Given this list of marker genes UNC93B1, TGFB1, YEATS2, BMPR1A, SCN1A, DNAI1, ADAMTS3, IRAK1, CD46, CTNND2, SH2B1, ZNF365, CFI, MDH2 (malate dehydrogenase 2), IFIH1, ANO1, ATRX, CDKN1B, HLA-B, TRAF7, SELENON, SLC25A4, ZFHX2, NFIX, IL12B, TNFRSF11A, HCRT, PIGA, GDF2, MAOA (NCBI Gene Id 441491), SAMHD1, NPPA, FAS, KIF23, TBC1D8B, TRAF3, SMAD3, MRPS2, MYD88, JAG1, CDKN2B, HELLPAR, CORIN, MAGI2, SMARCAL1, NOTCH2, PLAAT3, MSX2, DEPDC5, NR3C1, KCNA1, EPM2A, PDCD10, PRTN3, MECR, HLA-DPA1, GAPVD1, FASLG, SDHB, GNB2, MT-TL1, MEN1, MT-ND4, ITGA7, GP9, EPOR, MT-ATP6, STOX1, HLA-DQB1, SLC39A14, CCR1, TICAM1, SDHD, MLX, APC, TPM3, MT-TW, RNU7-1, RELN, SMARCE1, STIM1, SLC25A11, IL12A, UBAC2, ACP5, RNASEH1, JAK2, NOTCH3, PTPRO, FLI1, CDH23, ELANE, TBK1, SMO, EPAS1, AMACR, SPOP, C4A, LRP5, NOP56, TREX1, MT-TH, GABRG2, MOG, NRAS, SLC2A1, NAA60, PDGFRB, MLH1, MSH2 (mutS homolog 2), APOL1, HLA-DPB1, ESR1, USP48, HTRA1, NHLRC1, TPM2, CTLA4, TRPC6, LPIN2, PRRT2, KLRC4, POLG, RASA1, HTR1A, ZEB2, SCN2A, CSNK1D, CYP11B2, SMARCB1, NFE2L2, RAF1, ADAR, IL23R, ACVRL1, NUP85, PDGFB, SRPX2, NUP107, TNFSF4 (TNF superfamily member 4), SUFU (SUFU negative regulator of hedgehog signaling), CTNNB1, KCNJ5, TLR3, TTR, CASP10, ANKFY1, KYNU, GDF3, MARCHF6, RACGAP1, FLT1, ZFTA, NDP, TMEM127, AKT1, CPT2, PGK1, CACNA1A, MT-ND6, AMER1, KCNQ2, TWNK, SRSF2, PLCE1, CLCN2, STAT4 (signal transducer and activator of transcription 4), COL5A2, RNASEH2C, ACTA1, MCAT, NUP160, GP1BB, SLC12A3, PIK3CA, SEMA4A, RRM2B, ALK, CYB5R3, SMAD2, MTHFR, CFH, NLRP3, AIP, COL4A3, TRANK1, VANGL1, MPL, MRPL39, OPA1, NUP205, PMS2, CNTN2, SDHC, MT-ND1, USP8, TET2, RET, DNM1L, FGFR2, ASXL1, EMP2, SH2B3, PTEN, NF2 (NF2, moesin-ezrin-radixin like (MERLIN) tumor suppressor), CLCNKB, PAX2, BRCA2, SAT1, GCDH, TGFBR2, P2RY11, LSM11, IL10, ERF, RNASEH2A, STARD7, BRAF, NLRP12, NAGS, SLC19A2, HACD1, AP2S1, COPB1, RPS20, VHL, EPHB4, CD2AP, NPHS2, GP1BA, GATA2, COL1A1, KRIT1, MAP3K20, MSH6, EPCAM, LYN, RNF168, DNMT3A, GNAQ, TP53, GRIN2A, CTSH, PRORP, MEFV, ENG, KIT, KL, SLC1A3, SMAD4, VSX1, SAMD12, MYO1E, ANLN, POLE, MT-TF, LGI1, DKK1, IL12A-AS1, F8, MT-CO1, BCAT2, CACNA1D, WT1, PEX11B, CALR, FARSB, GPR101, NF1, MT-ND5, MUTYH, GDF6, CCND1, ACTN4, ACSF3, BAP1, CHEK2, POLG2, HLA-DRB1 (major histocompatibility complex, class II, DR beta 1), ADAMTSL1, CDKN1A, RYR1, RNASEH2B, FGFR3, MYORG, POLD1, IRF3, PIGT, SCN5A (sodium voltage-gated channel alpha subunit 5), MT-TC, TNF, CLTRN, IFNGR1, CRB2, KRAS, SPP1, CCM2, TLR7, CDKN2C, COL4A1, ATM, MT-TQ, PMS1, SQOR, MVK, TERT, ARHGDIA, GBA1, ADA2, COQ8B, MT-CO2, LIG3, DAAM2, THPO, KIF1B, P4HA2, MT-TK, COL3A1, ERAP1, PTPN22, SDHAF2, EDNRA, KCNK18, TWIST1, MT-CYB, NUP93, SLC6A19, SDHA, SOST, TNFRSF1A (NCBI Gene Id 8077), NUP37, ATP1A2, ALPK1, MT-TS2, CDC73, TLR4 (NCBI Gene Id 7099), MAX, MEOX1, MYL2, NUP133, SOX5, CNNM2, FRMD5, MT-CO3, NPHS1, ALX4, COL5A1 (NCBI Gene Id 1289), DLST, CYP11B1, ARHGAP24, APP, ATP1A3 (ATPase Na+/K+ transporting subunit alpha 3), FH, MT-TV, INF2, CMPK2, ADRA2B, here is a description of the gene set: studied in species Homo sapiens Headache Cephalgia, or pain sensed in various parts of the head, not confined to the area of distribution of any nerve. Human Gene Set: HP_HEADACHE